The following is a description of a gene set: Genes up-regulated in KLRG1 low CD8 T effector cells during infection: ID2 and BCL2L11 versus BCL2L11 knockout. Human Gene Set: GSE41978_ID2_KO_AND_BIM_KO_VS_BIM_KO_KLRG1_LOW_EFFECTOR_CD8_TCELL_UP CD8+ T cells play a crucial role in the clearance of intracellular pathogens through the generation of cytotoxic effector cells that eliminate infected cells and long-lived memory cells that provide enhanced protection against reinfection. We have previously shown that the inhibitor of E protein transcription factors, Id2, is necessary for accumulation of effector and memory CD8+ T cells during infection. Here we show that CD8+ T cells lacking Id2 did not generate a robust terminally-differentiated KLRG1hi effector population, but displayed a cell-surface phenotype and cytokine profile consistent with memory precursors, raising the question as to whether loss of Id2 impairs the differentiation and/or survival of effector-memory cells. We found that deletion of Bim rescued Id2-deficient CD8+ cell survival during infection. However, the dramatic reduction in KLRG1hi cells caused by loss of Id2 remained in the absence of Bim, such that Id2/Bim double-deficient cells form an exclusively KLRG1loCD127hi memory precursor population. Thus we describe a role for Id2 in both the survival and differentation of normal CD8+ effector and memory populations. from publication Knell J, Best JA, Lind NA, Yang E, D'Cruz LM, Goldrath AW (PMID 23325888) studied in species Homo sapiens, and this is the list of marker genes: SNTB1, RPS6KB2, EPS8L1, SLN, FCER1A, C1S, SARS2, RNF25, ADI1, MPP2, ELOVL2, FBLN1, OASL, MED19, CA6, GNG13, TRPC4, POU4F3, TOMM7, SIT1, LAMB2, ITGA6, BVES, HOMER2, UGT8, NOTCH1, ATP8A1, LAMP2, SH2D1A, CHST1, CGREF1, VWA7, DAPK3, EPS15L1, CACUL1, ELF4, NMU, KLF3 (NCBI Gene Id 51274), EEF2K, MSH3, LAPTM4A, EPHA4, PDPN, MAML2, LYZL4, CTSF, EME1, FA2H, MGST1, IRF2BP1, CPLX3 (complexin 3), NNMT, PRUNE1, HBE1, SALL3, VMP1, CLEC6A, ERMP1, S100G, SIRT4, TGFBI (transforming growth factor beta induced), UPF2, PCSK2, MAGIX, PDE6G, GNAT2, BCAM, CASP8AP2, LMAN2, ZMAT2, GPRC5C, NUP42, PCP2, IFT22, YEATS4, AKR1D1, KLK10, UNK, TAPBPL, TUSC2, ANGEL2, DNER, ZIK1, DEF8, GSPT2, ATG101 (autophagy related 101), LINC00612, BAP1 (NCBI Gene Id 8314), CYP19A1, PLBD1, NAT8, CPNE3, ARHGEF12, SKAP2, NME3, SLTM, RHEBL1, GPNMB, NME4, KPLCE, DUSP19, POLR1H, GRIN2C, GP9 (NCBI Gene Id 2815), RBM4B, NCAPG2, LFNG, C1orf159, ORM2, PPP1R14C, PHYH, GAS1, PLOD1, SOX3, POPDC3 (NCBI Gene Id 64208), MFSD3, TFEC, RIMOC1, FAM53C, ZDHHC3, XIAP, PTPRG, CLEC4E, FOXD4L1, DCX, PTPRF, TMEM19, INMT, HOXA9, MTMR10, MCM9, APIP, LSM5 (LSM5 homolog, U6 small nuclear RNA and mRNA degradation associated), SAA1, DRAM1, CD5, FERMT2, WDSUB1, TMEM131L, FN1, TMEM9, GJC2, NBEA, PITX2, TBX15, THTPA, ATF2, NTF3, SP2, STAM2, RPP21, C15orf39, RAB33B, PLA2G10, CD14, CHIC1, SLC5A4, POF1B, PDLIM5, RUFY3, FADS3 (fatty acid desaturase 3), FUT7, ENPP1, FAM3B, MSR1, TMPRSS13, INSR, WRAP73, MYOD1, MKKS, EPHX1, SLC25A23, CD34, TMEM106C, DPM2, PTGER1, RDH10, BUD13, PISD, SYT10, NAPB, BPGM, HCK, SLC25A38, CLCN2, CCL1, TENM1, ARHGAP31, MS4A3, SLC4A5, AGBL3, C11orf71, UQCRC1, SLC7A2, VKORC1, CHAD, IGFBP5, CDCA5, CIBAR1